The following is a description of a gene set: studied in species Homo sapiens Human Gene Set: GOCC_OUTER_MITOCHONDRIAL_MEMBRANE_PROTEIN_COMPLEX Any protein complex that is part of the outer mitochondrial membrane., and this is the list of marker genes: TOMM70, TOMM22, HSPA9, APOO, MTX3, TOMM5, TOMM20, TOMM20L, TOMM6, TOMM7, MTX1, APOOL, TOMM40L, DNAJC11, MICOS10, CHCHD6, TOMM40, MICOS13, MFN1, MTX2 (metaxin 2), IMMT, CHCHD3, SAMM50